Given this list of marker genes MAPT, PLP1, GRN, CHMP2B, PSEN1, APOE, PSEN2, TREM2, TMEM106B, here is a description of the gene set: species: Homo sapiens An inability to name people and objects that are correctly perceived. The individual is able to describe the object in question, but cannot provide the name. Human Gene Set: HP_ANOMIC_APHASIA Anomic aphasia